Given this list of marker genes Adcy10, Sri, Zc3h12a, Pde5a, Bin1, here is a description of the gene set: Mouse Gene Set: GOBP_NEGATIVE_REGULATION_OF_CARDIAC_MUSCLE_CONTRACTION Any process that stops, prevents, or reduces the frequency, rate or extent of cardiac muscle contraction. species: Mus musculus